The following is a description of a gene set: studied in species Homo sapiens The process in which nerve cells are generated. This includes the production of neuroblasts and their differentiation into neurons. Human Gene Set: GOBP_GENERATION_OF_NEURONS, and this is the list of marker genes: RHO, NDEL1, RUNX3, SIX4, FAM151B, TBX20, POC5, ZNF365, GRXCR2, GRIP1, POTEE, LZTS1, IL15RA, MINK1, RAB8A, SMIM45, CASZ1, RNF7, CUL7, BIN1, COL25A1, ZIC3, TOP2B, CC2D1A, ALK, WNT5A, BTG4, CAMSAP3, DMRTA2, RAB17, DIXDC1, LMX1B, TECTA, PAX7, CDH1, JUN, BMP7, FARP1, ABI1, TRIM67, EPHA8, DVL1, DVL2, NEUROD1, TNFRSF12A, LHX4, STRN, SOX4, MYO16, ERCC6, NIPBL, PTPRS, FRYL, NRBP2, FOXO3, TRIM46, NEO1, OTX2, BCL2, SGK1, NFATC4, IGF2BP1, MIR431, BRINP2, ALCAM, GABRB2, LAMA1, GPX4, LIMK1, FILIP1, ARHGAP33, ITGA6, LHX1, PPP3CA, PDLIM5, CREB1, PTPRH, NKX2-1, UBE4B, NFASC, ARFGEF1, ROBO3, STX3, LGI4, SEZ6, DZANK1, EFNA2, EML1, AKT1, CTNNB1, TENM4 (teneurin transmembrane protein 4), SOX12, TAOK3, CAMK2B, FRY, CYFIP2, APBB1, MFSD2A, NEU4, ADGRV1, HMG20A, BLOC1S5, BNIP2, PLPPR5, PAQR3, KIF5B, TMEM132E, PTK6, MINAR2, RP1, SOX1, CCDC88A, HIPK1, S1PR1, SOD1, AVIL, FBXO7, ZNF804A, GDF7, DCC, NIN, AMIGO3, CRTAC1, DISP3, CPNE6, NCAM1, NTF4, NPTX1, NPY, SEMA6D, WNT2, B3GNT2, NKX2-8, CLMN, HEY1 (hes related family bHLH transcription factor with YRPW motif 1), FLRT2 (NCBI Gene Id 9822), AGBL4, XRN2, ASTN2, PALS1, CDKL3, CDK5, MAP2K1, FKRP, BTBD3, DIP2A, PTPRT, TMC1, PROX1, MUL1, TUBA1A, HERC1, POU4F2, MAP2, ERBB4, ATXN10, NLGN1, SDK1, VCL, PARP6, SCRT1, EHD1, CLN5, HEY2, HMGB1, MATN2, EPHA6, WDR62, KCNIP2, SFRP2, FKBP8, MAPK8IP2 (mitogen-activated protein kinase 8 interacting protein 2), GATA3, CSNK1D, ALKBH1, EFNA4, GSK3B, RB1, HSP90AA1, SCN11A, DVL3, SLC23A2, SLITRK2, INPP5J, MDM2 (NCBI Gene Id 84825), HDAC6, CIT, LRP4, CASP3, DKK1, GPRIN1, ROM1, NEUROG2, SEMA4B, CDH4, RAP2A, EIF4E, EN2, DAB2 (DAB adaptor protein 2), KIAA1755, CRB2, GDNF, APOE, LHX9, LYPLA2 (lysophospholipase 2), PRKN, WASHC5, MICALL1, ATAT1, MACF1, IGSF10, APLP2, APBB2, CAMSAP1, ESRP1, CARM1, FLRT1, NSMF, LAMA2, NR4A2, PCDH12, DAG1, MGARP, SCLT1, PAK3, CPNE9, METTL14, MYPN, GBA2, GFI1, LSM1, RTN2, TRAPPC4, NCS1, RETREG3, CTHRC1, TCTN1, KLHL1, LPAR3, SMARCD3, GALR2, IL1RAPL1, ASCL1, TTC36, APLP1 (amyloid beta precursor like protein 1), TNXB, GORASP1, IGSF9, LHFPL5, FUT9, MANF, NGF, FGF8, EPHA7, CAMK2G, NTRK2, CTDSP1, FYN (FYN proto-oncogene, Src family tyrosine kinase), B4GALT5, FAIM2, CERS2, RAB10, STXBP1, PEX5, JAK2, ADRA2B (NCBI Gene Id 151), KCNA1, DAGLA, EIF2AK4, GDPD5, ATP7A, DNAAF4, CABP4, TP73, PTN, SDK2, NAP1L2, NFE2L2, ZDHHC16, NGEF, LBX1, SPTBN4, GSX2, TGIF1, FZD7, TP53, BTG2, RELN, EFHC2, NUMB, RAB3A, TWF2, SPINK5, UGT8, FOXP2, IFT172, MYLIP, ACTL6B, RTN4R, TNIK, SS18L1, TRIP11 (thyroid hormone receptor interactor 11), ZNF296, PAK1, WASF2, MIR133B, CAMK1D, MEF2C, EFNB2, MTR, GNAT2, PLXNA1, NTN3, DHFR, CYB5D2, CHRNB2, ADARB1, MAP1S, NIF3L1, MIR219A1, LARGE1, NRL (NCBI Gene Id 4901), ANK3, ZSWIM6, MDK, MYOC, SCYL1, ABI3, DIAPH3, NEUROD2, SLIT2, BCHE, ALKAL1, POTEF, SHOX2, DSCAML1, NOVA2, PICK1, EPG5, ALDH1A2, AFG3L2, ZEB1, WNT3, SPAG9, AHI1, LHX2, RAB37, BHLHE23, ZDHHC15, LHX8, STX1B, PRDM13, MED1, HDAC5, CDKN1C, CUL5, GAK, SLC39A12, USP9X, EXT1, NGFR, DAGLB, YWHAZ, INPP5F, CDON, IFT140, NPR2, SEMA5A (NCBI Gene Id 9037), MYCL, EPHA10, SIAH1, UNC5B, SATB2, IQSEC1 (IQ motif and Sec7 domain ArfGEF 1), PLEKHG4, PRDM12, SCRT2, EMX1, GABRA5, PTPRU, B4GALT6, ZNF536, NDRG4, SOX9, YWHAE, EN1, GDF11, ONECUT2, TRIO, ULK4, RTN4RL2, ZNF335, ITGA3 (NCBI Gene Id 4454), MECP2, EPHA5, TAOK1, TGFB1 (transforming growth factor beta 1), VEGFD (NCBI Gene Id 2277), SPG11, CHD5, MAPK6 (NCBI Gene Id 5597), SERPINI1, PLXNA3, ARF4, RAP1GAP, LLPH, GRXCR1, UGCG, EVL, SNAP25, PAK4, TLX3, TCF4, FZD8, DGUOK, GHRL (NCBI Gene Id 51738), FEZ1, FOXD1, USH1G, NOG, EPHB2, RARA, FGF20, ABL2, SHANK3, KCNQ3, GBX1, ADCY1, IFT27, FES, ADAM17, WNT16, AGER, FLOT1, MMD, CPNE1 (NCBI Gene Id 8904), GAS6, VSX2, CRKL, TENM2, SPART, TLX2, CXCL12, PTPN11, PLXNB1, SCARB2, RTN4, TGIF2, FGF13, ID1, GPC2, WNT9A, VPS54, NMNAT2, SOX3, GLI2, LAMB1, CDNF, SHOC2, COBL, HS6ST1, OSTN, COL3A1, CCDC39, ETV5, THRB, DAB2IP, SOX15, SLC1A3, TTLL1, ACP4, BCL11A, IER2, XBP1, HEYL, DUOXA1, CNTNAP2, NRCAM, LONRF2, SARM1, FSHR, SOX10, SLC4A10 (solute carrier family 4 member 10), FZD10, MFSD8, PTPRO, RND2, NLGN4X, RORA, FERD3L, IFRD1, FRMD7, GABRB1, TRIOBP, CLN8, ITSN1, GAREM2, APOD, MYO9A, SPRY3, MAPK8IP3, HIF1A, FIGNL2, SIN3A, MDGA2, SLC30A1, C1QA, DBNDD2, RERE, AP2A1, ZMIZ1 (zinc finger MIZ-type containing 1), BECN1, DLX3, PPP1R12A (protein phosphatase 1 regulatory subunit 12A), DDX56, NEDD4, PLXND1, PBX2, STAU2, CELSR1 (NCBI Gene Id 9620), DBN1, MICALL2, VAPA, PLXNA4, PPP1R9B, DLX1, NCK2, REST, B2M, FGFR2, GAP43, BOC, SLC44A4, RPGRIP1L (RPGRIP1 like), SOX21, SYT3, EFNA5, SEMA4F, HELT, PJVK, SCARF1, KDM1A, CD38, PACSIN1, EVX1, ACAP3, RAB11A, GNGT1, LRRC7, AKNA, FEZF1, ANKRD27, WASF1, ZEB2, XK, CHRNA7, LST1, LNX2, CCND1, PQBP1, BSG, SDCCAG8, TRAK1, POTEKP, TANC2, FGF2, DHX36, EFNB1 (ephrin B1), MAPKAPK5, RIMS2, ITM2C, OGDH, MYCN, PTPRJ, DOCK10, PRPH2, RAB13, RTN4RL1, DICER1, TAFA1, LPAR1, DTNBP1, GRID2, OLFM1, VWC2, ARHGEF28, PSD, KIF5A, CFL1, PHGDH, UST, SNX3, RAPGEF2, CECR2, MYOT, DNER, BRSK1, PLXNB2, SLITRK3, CDK6, PHACTR1, JAG2, SOX14, EDNRB, PAFAH1B1, AIFM1, PPP1R9A, EGFR, NFIA, EPB41L3, STRC, CPEB3, CTTN, MBOAT1, CCK, RIT2, NTM, LDB1, DLX5, MAP3K13, PLPPR4, ULK1, GNRH1, COPS2, KIFBP, KIF21A, SCYL3, SYT4, TOR1A, LHX3, LGI1, ARHGAP4, NKX6-3, ATF4, NDP, FOXA1, AUTS2, VIM, PSEN1, MYT1L, SYT14P1, ARHGEF40, TSKU, WNT4, GPRIN3, OTP, CIB1, IFT20, MAG, BAIAP2, SOCS7, TUBB2A, C12orf57, NGRN, BHLHA15, MAP7D2, NTF3, EP300, ADCY10, DIO3, FSCN2, SLC11A2, ELP6, CLSTN3, CACNG7, KIF5C, FZD3, HES1, CCKAR, PREX2, PTPRD, CD3E, EPHA2, CRK, FZD1, DPYSL5, PCDHAC2, STMN1 (NCBI Gene Id 3925), CNTN1, PMP22, SLC4A7, TENM3, NTN1, SLIT1, NKD1, RPGR, NEFL, NTNG1, OPCML, ERCC2, MEGF8 (multiple EGF like domains 8), METRN, PPP1R12C, NEXMIF, ST8SIA2, HPRT1, SH3GL3, SOCS2, CNTN4 (NCBI Gene Id 53943), ANAPC2, MIR146A, VSX1, MET, FMC1, BMP5, THY1, EPHB1, CNR1, DRD1, EPOP, ATP2B2, NHLH2, RAB6A, TSPO, HCN1, C1QL1, NR2E3, MFRP, OLIG3, ERBB2 (NCBI Gene Id 2064), LRIG2, NBN, UCN, HOXA2, SKIL, VWC2L, FOXG1, PLAA, BBS10, TUBB3 (NCBI Gene Id 94749), UNC5C, MAP1B, ANKRD24, MICOS10-NBL1, MYO6, KIF20B, EFNB3, CTNND2, STAT3, HIPK2, ADGRF1, CRB1, AURKA (NCBI Gene Id 8465), MKS1, BMPR1A, ISL1, C21orf91, SIX1, RPGRIP1, MYEF2, NELL2, NECTIN1, POTEI, DLL4, CAPRIN2, TH, NFE2L1, L1CAM, MIB1, STMN2, SOX5, ARF6, TUNAR (TCL1 upstream neural differentiation-associated RNA), NTRK1, GDF6, PARD6B, TIAM2, CRMP1, DBNL, BMPR2, YTHDF1, NKX6-2, ZMYND8, DMD, FRS2, UQCRQ, SCYL2, FZD9, NPHP4, STRAP, GPR37, FOLR1, WNT6, ARL3, TGFBR1, TUBGCP2 (NCBI Gene Id 10844), CUX2, BRSK2, SCN1B, SIX3, SETX, ABITRAM, PHOX2B, TRAPPC9, VAX2, RAB6B, NR2F2, CNTF, PAK6, BBS1, SEMA5B, GLI3, SYNGAP1, PRKCI, FZD2, DRGX, GPR173, SEMA3B, NKX6-1, NRN1L, ADGRB3 (adhesion G protein-coupled receptor B3), NEPRO, WNT2B, NYAP1, NRTN, NUMBL, PTK2, KEL, ANOS1, ADCYAP1, CDK16, PHOX2A, PLK5, FAT3, POTEJ (NCBI Gene Id 653781), GBA1, GAS7, PAK2, TBR1, CPNE5 (copine 5), SLC12A5, B4GAT1, ERCC3, WDPCP, PLP1, SDC2, ATG16L1, GPR37L1, TRPV2, GRIN3A, P3H1, GRM7, SULT4A1, ITGB1, GDF5, MMP2, NCKAP1, TMEM106B, OLIG2, TPRN (taperin), TSPAN2, WHRN, OLFM3, GIGYF2, MIR137, CHRNA3, HOXD10, SERPINF1, LMX1A, CYFIP1, RTN1, EPO, HOXC10, SYN1, SDC4, ROBO2, RFX6, FN1, DDR1, AP5Z1, STYXL1, MTMR2, KLK8, KCNQ1, ELAVL4, INSM2, WNT5B, INS, NAV1, FMR1 (NCBI Gene Id 5421), PTPRF, PRKG1, NEGR1, ID3, PRKCA, PCARE, CAMK1, LRP12, PPP2R3A, EYA1, DDR2, CDH11, FZD5, SMURF1, ARC, DRD2 (dopamine receptor D2), CX3CL1, WNT7A, DLG4 (discs large MAGUK scaffold protein 4), DNMT3A, EZH2, KLF7, CFLAR, CRPPA, GFAP, TAL1, KLF4, RSPO2, OPHN1, TTL, WEE1, ZNF521, NAGLU, RTN4IP1, ZHX2, ECE1, ID4, DRAXIN, DISC1, PICALM (NCBI Gene Id 8301), PROM1, CLASP2, PCM1, PTPN1, WNT1, SEMA3F, ACTB (NCBI Gene Id 60), LTK, LYN, VAX1, NTN4, PPIA, ARTN, KHDC3L, SEMA3A, HHIP, RUNX2, PPP2R5B, PRDM1, TULP3, HMCN2, ADCY6, NRG3, RAB29, SAMD14, SCRIB, VXN (vexin), KALRN, SOX8, EPHA3, YWHAH, TBCE, DSCAM, SRGAP2 (SLIT-ROBO Rho GTPase activating protein 2), SRGAP2C, ARK2C, BICDL1, KAT2B, DPYSL3, RET, FOXN4, SMO, TNR, SLC38A8 (solute carrier family 38 member 8), EDN2, SLC25A46, BMP2, MIR222, SLIT3, IRX1, VPS13B, MIR221, SALL1, PLXNC1, WNT9B, NHERF1, MAP4, CTNNA1, ALS2, ADNP, NTRK3, RNF112, C3, ROBO4, CBFA2T2, ABT1 (NCBI Gene Id 29777), SRRM4, KIAA0319, CHODL, RND1, TEAD3, TTC8, HTRA2, ULK2, PTBP1, TBCD, ISLR2 (immunoglobulin superfamily containing leucine rich repeat 2), RASGRF1, ATP8A2, MIR125A, PRKD1, PITX2, FLRT3, NEUROG3, DOCK7, ATP9A, ZC4H2, CSF1R (colony stimulating factor 1 receptor), HDAC2, IFT88, SPAG6, TBC1D23, KIDINS220, ACSL6, MDGA1, FOXO6, TWIST1, FZD4, UNCX, PAX2, PTPRK, ARHGAP44, DMRT3, FUOM, NOTCH2, SEMA4D, STK25, PCSK9, ELMOD3, SEMA6A, KIF26A, NDN, MAP4K4, EMB, NRP2, SOD2, CAMSAP2, NOTCH3, CEP85L, WNT7B, GPM6B, PLEKHG4B, SOX11, KNDC1, FOXB1, ADGRL3 (adhesion G protein-coupled receptor L3), CEBPB (CCAAT enhancer binding protein beta), FEZF2 (FEZ family zinc finger 2), SPP1, PTPRM, POU4F1, DLG5, IL2, RYK, ABLIM1, ARHGAP35, SLITRK4, MEIS1, PREX1, S100B, VEGFC, DYNC2H1, IRX4, PTPRG, IRX5, SYT17, TPBG, SMAD1, APOA4, FEZ2 (fasciculation and elongation protein zeta 2), RUFY3, AMIGO1, PGRMC1, NR2E1, PPP1CC, RHOA, MTCH1, RPS6KA5, UGDH (NCBI Gene Id 7358), ISL2, SEPTIN4, ACSL4, SRCIN1 (SRC kinase signaling inhibitor 1), LGR6, CNTN2, NCOA1, RAPH1 (Ras association (RalGDS/AF-6) and pleckstrin homology domains 1), AXL, SLITRK5, LHX6, DCT, SEMA6C, KIRREL3, GPRASP3, DCX, BARHL1 (BarH like homeobox 1), MTPN, CDC27, NPTN, GPM6A, INHBA, EHMT2, TAOK2, C9orf72, SPOCK1, SLITRK6, WASL, NYAP2, UNC5D, EDNRA, VCAM1, CD2AP, BLOC1S1, PIN1, PEX13, TBX6, SEMA3D, POU3F2, RDH13, ETV1, ASPM, EOMES, UNC13A, SEMA4A, CLRN2, SOS1, EGR2, KREMEN1, TULP1, NEUROD4, NCKIPSD, RAP1A, CDHR1, MEF2A, CTF1, SEC24B (NCBI Gene Id 10427), PTEN, CDC42, RAC1, VPS13A, TRPV4, NRN1, LRRC4C, HECW1, GSDME, RORB, ZFHX2, IRX6, NRXN1, RAB35, THAP11, ARX, HOXC8, KIAA0319L, HES5, ZNF609, FOS, NRDC, BRAF, RGMA, DNM2, ONECUT1, PDE6C, PBX3, PRICKLE1, BORCS7, WNT8A, SH3GL2, HERC2, IST1, NCKAP1L, THOC2, EIF4G1, IMPACT, SAMD11, TRAK2, ENC1 (ectodermal-neural cortex 1), NEFH, TENM1, POU4F3, VASH2, ABL1, NANOS1, HDGFL3, JAG1 (NCBI Gene Id 3715), PITX3, HMG20B (high mobility group 20B), METTL3, TGFB2, IQGAP1, ANKRD1, LRRK2, LAMB2, TWF1, CFAP418, ROBO1, STMN4, TOX, CDK5RAP2, RPL24, KCTD11, PRKCZ, GSX1, ALKAL2, ATP1B2, CX3CR1, CALR (calreticulin), ADGRB1, CDK5RAP3, BLOC1S2, ZDHHC17, SHANK1, WNT10A, FOXA2, DHFRP1, OMG, CHN1, SEMA3E, CUX1, TNN, EMX2, ENAH, EFNA1, GABRB3, DCDC2, DENND5A, PIGT, TNC, PUM2, NRP1, PPFIA2, RTCA (NCBI Gene Id 8634), ACTG1, ARHGEF25 (NCBI Gene Id 115557), KANK1, ATOH1, HDAC1, TSC22D4, CLRN1, DLX2, UNC5A, TRPC5, SMARCA1, S100A9, SPAST, PBX1, BBS4, FBXO38, PRRX1, PITPNA, MAP6, UHMK1, RASAL1, DGKG, CEP290, LRP8, NBL1, PARD3, RTN3, MCOLN3, VASP, CELSR2, ACSL3, SECISBP2, NCDN, SKOR2, GIT1, EPHB6, ELP3, NOTCH1, EPHA4, CCR4, LEF1, USP33, ITGA1, ATF1, ASTN1, ARMCX5-GPRASP2, WNT3A, BLOC1S6, CNGB1, SEMA4G, PPP1R12B, LZTS3, CDKL5, LRP2, ACTBL2, SEMA4C, SFRP1, WDR47, BHLHE22, SF3A2, GPRIN2, ARHGEF2, SSNA1, FARP2, BCL7A, KCNB1, VANGL2, UBB, NR2F1, ASCL2, OBSL1, CNP, NLGN3, SUFU, RAPGEF1, SEMA6B, TDP2, SLC6A4, S100A6, BCCIP, NAPA, CEND1, CELSR3, IHH, FSTL4 (NCBI Gene Id 23105), BEND6, ERBB3, BLOC1S4, VRK1 (NCBI Gene Id 7443), AGTPBP1, KIF1A (kinesin family member 1A), GFRA1, ACTL8, ADORA2A, LMO4, ADRA2C, EIF4ENIF1, HOXD3, TCF12, TMEM30A, PTPN9, ZPR1, ROCK1, PRKCQ, EDN1, MOSMO, SYT1, DAB1, NR2F6, STMN3, NREP, ZFHX3, FIG4, NDNF, BAX, BRINP3, SEPTIN14, IRX2, DDX6, BRINP1, VEGFA, FGFR1, CSMD3, ECT2, SOX2 (NCBI Gene Id 6657), MNX1, MIR200C, CTNNA2, MCF2, BDNF, RNF220, BCL6, ZFYVE27 (zinc finger FYVE-type containing 27), PPP3CB, HEXA, PTK2B, HOXD9, FLNA, CDK5RAP1, PPT1, CNTN5, MYCBP2, HOXD1, CDH23, MARK2, PALLD, NDE1, GFRA3, NR4A3, MINAR1, CDK5R1, KLK6, MT3, SH3RF1, WNT8B, SYT2, EFHD1, TMEM108, OTOGL, SIPA1L1, DCLK1, SVBP, SAMD7, BAG5, NKX2-2, GLDN, NCAM2, IRX3, CNTNAP1, GDI1, TUBB2B, INSM1, ABI2, RUNX1, MAP1A, MYH10, FEV, SRF, IL6, CRABP2, DCLK2, POSTN, AREG, NCK1, DLL1, BCL11B, BMP6, DTNB, RBPJ, MIR210, MMD2, OLIG1, GATA2, ATCAY, DTX1, KIFAP3, YWHAG, SMAD4, WNK1, HECW2, FBXW8, CHL1, LEP, UNK, LLGL1, GRN, USH1C, PTCH1, SLITRK1, ID2, VLDLR, MAPT, WNT10B, PRDM8 (NCBI Gene Id 56978), ATOH7, FBXO41, DDIT4, BARHL2, AGRN, ATL1, LIN28A, PLS1, GSK3A, EDN3, BLOC1S3, USH2A, MYO7A, RNF157, MARK1, PEX7, LIF, EFNA3, DIP2B, NEDD4L, SEMA3C, GPRC5B, NKX2-5, NEUROG1, PBX4, CDK5R2, SNPH, KIF13B, TCF3, NOTO, TTC21B, TNFRSF21, ATP8B1, ITSN2, APP, BMP4, RGS2, PDZD7, NF1, NLGN2, RACGAP1, PAX6, KATNB1, ZNF212, PTF1A, MAP2K2, EPHB3, FBXO45, MOV10, NRXN3, CNTN6, PRMT1, ITPKA, SZT2, RAC3, RP1L1, TRPC6, TFAP2C, CDC20, ITGA4, LHX5, PLXNB3, OR10A4, TBC1D24, SHTN1, LRP6, SPG21, SEMA7A, RIMS1, GOLGA4, ATF5, SHH, NEUROD6, WNT11, TYRO3, NTNG2, MAGI2, SEMA3G, DBX1, PLA2G10, PCP4, SLC9A6, BMPR1B, GBX2, FKBP4, CAMK2A, CBLN1, POMGNT2, NEXN, NFIB, STK24, ADGRG1, PLA2G3, PTPRZ1, TRIM32, UCHL1, SNAPIN, EEF2K, PRAG1, CAPRIN1, DOK5, STK11, GNAT1, NEURL1, UPF3B, KIFC2, PTK7, HAND2, ARSB, ANKS1A, RAB21, TIAM1, RNF6, MIR511